Given this list of marker genes CHCHD1, AP3S1, HTR4, MEF2A, TESC, MSRA, VNN1, BIK, EXOSC4, MKNK1, SUCNR1, MOB1A, KLK4, TIMP1, DDAH2, SLPI, CLEC4D, XRN2, KIFC3, FIGN, PPM1M, ARL8A, CFAP73, GPR84, EMC7, FBXO9, BATF, MTIF3, OTOP2, GYG1 (glycogenin 1), S100A6, SCD, SYT6, RCHY1 (ring finger and CHY zinc finger domain containing 1), ANO10, P4HA2, ALPL, UNC5A (unc-5 netrin receptor A), SPC24, DCTN2, ACAA1, ZDHHC19, ITGA7, DNAH10, CMTM1, GRINA, NLRC4, SEC14L4, CAMTA2, VGLL3 (vestigial like family member 3), SLC27A2, ABCC2, STXBP2, SDHC, SLURP1, AP3S2, APH1B, PDGFC, CD59, ROM1, ADAM10, CEBPE, VKORC1, CTNNA3 (NCBI Gene Id 50620), FOLR3, GPR32, GALNT14, SQOR, DNASE1L1, MCU, GNA15, CIDEB, SCAND1, F5, PSMD9, PODNL1, MYD88, RNF7, LACTB, PIWIL4, TSPO, USB1, CAPN13, SEMA4G, ANKRD33, SPPL2A, PEF1, RNF10, RHBDD2, GFOD2, SIRT2, TPK1, CSN1S2AP, LINC01545, CTSG, LINC00482, LAMTOR2, LINC00307, CYSTM1, PRKAA1, SNX3, KLF7, TLN2, KIF18B, GSTO1, NAIP, C14orf119, ZNF219, HPSE, SLC22A4, MROH6, TDRD9, CST7, BLOC1S1, MKI67, PHAF1, MSRB3, ROMO1, GLTP, KIF1B, RAB1B, ARHGEF17, PLAC8, RDH5, KIAA2013, GBA1LP, PROX1, OPLAH, RAB11A, SIRPD, TMEM92, ATOX1, IRAK3, MYL6, HTRA3, AKIRIN2, HIF3A, TWF2, DSCC1 (DNA replication and sister chromatid cohesion 1), CUTC, CTAGE9, CYP21A2, SLC22A23, UBE2A, PSAPL1, LRPAP1, FHIP1B, GGT1, IRAG1-AS1, PRDX5 (peroxiredoxin 5), HOXC13, MPO, CASP5, MAPT-AS1, MICU1, TUBGCP3, PGS1, TIMM8B, ANAPC15, TMEM11, SRA1, CAPN3, GNG5, CARD6, GADD45A, MAP2K6, CALM3, LINC00671, RETN, GIT2, MTF1, NDUFC2, ACTR1A, S100A4, MROCKI, UPP1, NDUFAF1, CFL1 (cofilin 1), NME8, CD63, PLB1, APOBEC3D, KIF3C, MAJIN (membrane anchored junction protein), FAM171A2, CD177, PIK3AP1, MSL3, RAP2C, ZNF319, FBXL19, AMPD3 (adenosine monophosphate deaminase 3), NOL3, DPY19L3, B3GNT5, VOPP1, CAB39, HK3, here is a description of the gene set: Human Gene Set: GSE7400_CTRL_VS_CSF3_IN_VIVO_TREATED_PBMC_DN Genes down-regulated in comparison of untreated peripheral blood mononuclear cells (PBMC) versus PBMCs treated with CSF3. Granulocyte-colony stimulating factor (G-CSF) is used to boost granulocyte counts in immunocompromised patients, but its effects on the immune system may be counter productive. We tested the hypothesis that G-CSF mobilized peripheral blood stem cell (PBSC) products are immunologically down regulated based on gene microarray analysis. Ten peripheral blood samples from normal donors for allogeneic PBSC transplantation were obtained before and after administration of G-CSF and tested on Affymetrix Human U133 Plus 2.0 GeneChip® microarrays. Significant changes in gene expression after G-CSF mobilization were reported by controlling the false discovery rate at 5%. Immune-related genes were isolated from the data set and categorized according to probe set annotations and a thorough, independent literature search. We found that G-CSF up-regulated inflammatory and neutrophil activation pathway gene expression; however, adaptive immune-related gene expression, such as antigen presentation, co-stimulation, T cell activation and cytolytic effector pathways, were generally down-regulated. Thus, despite significant increases in stem cells, lymphocytes and antigen presenting cells, G-CSF mobilized PBSC allografts exhibit a suppressive adaptive immune-related gene expression profile. Our data provides an explanation for the potentially immunosuppressive effects observed after G-CSF administration. studied in species Homo sapiens from publication Buzzeo MP, Yang J, Casella G, Reddy V (PMID 17761290)